The following is a description of a gene set: from publication Chen Y, Wang X (PMID 31504780) Mouse Gene Set: MIR_3569_5P species: Mus musculus Genes predicted to be targets of miRBase v22 microRNA mmu_miR_3569_5p in miRDB v6.0 with MirTarget v4 prediction scores > 80 (high confidence targets)., and this is the list of marker genes: Ube2z, Htra1, Ccdc92, Cimap1d, Nacc2, Ttc1, Uhmk1, Hnf4a, Ptprf, Coq8b